The following is a description of a gene set: Any process that activates, maintains or increases the frequency, rate or extent of synapse assembly, the aggregation, arrangement and bonding together of a set of components to form a synapse. Mouse Gene Set: GOBP_POSITIVE_REGULATION_OF_SYNAPSE_ASSEMBLY species: Mus musculus, and this is the list of marker genes: Flrt3, Lrrtm2, Slitrk1, Bhlhb9, Ptprd, Sema4d, Adgrl1, Flrt1, Eef2k, Lrrtm3, Iqsec1, Adgrl3, Lrrc4b, Oxtr, Slit2, Stau2, Slitrk4, Amigo1, Vstm5, Ntrk1, Syndig1, Thbs2, Musk, Adgrl4, Xlr3b, Grid2, Adgrb2, Lrtm2, Slitrk3, Lrrn3, Clstn1, Adgre5, Ephb2, Tpbg, Amigo2, Ube2v2, Adnp, Nrxn1 (neurexin I), Slitrk6, Slitrk2, Pik3r1, St8sia2, Il1rap, Ephb3, Cbln2, Wnt7a, Agrn, Dlg5, Srpx2, Gsk3b, Lrtm1, Prkca, Dlg4, Amigo3, Ntrk2, Adgrl2, Ghrl, Il1rapl1, Lrrc24, Oxt, Nlgn2, Cux2, Ephb1, Clstn2, Lrrn1, Bdnf, Adgrb1, Lrrtm1 (leucine rich repeat transmembrane neuronal 1), Lingo2, Lingo4, Nlgn1, Slitrk5, Actr3, Sema4a, Asic2, Nlgn3, Flrt2, Adgrb3, Lrrtm4, Ntrk3, Clstn3, Cbln1, Efna5, Iqsec2